Given this list of marker genes SC5D, SQLE, FDFT1, MVD, DHCR7, CYP51A1, IDI1, LSS, NSDHL, MVK, HMGCS1, MSMO1, HMGCR (3-hydroxy-3-methylglutaryl-CoA reductase), PMVK, FDPS, here is a description of the gene set: studied in species Homo sapiens Human Gene Set: WP_CHOLESTEROL_BIOSYNTHESIS_PATHWAY Cholesterol biosynthesis pathway